Given this list of marker genes Tln1, Pde5a, Myl6, Gucy1b2, Itgb5, Actg2, Tpm2, Myl7, Lmod1, Calm1, Pxn, Myl9, Gucy1b1, Tpm3, here is a description of the gene set: species: Mus musculus electronically inferred by orthology from the curated human pathway This event has been computationally inferred from an event that has been demonstrated in another species.<p>The inference is based on the homology mapping from PANTHER. Briefly, reactions for which all involved PhysicalEntities (in input, output and catalyst) have a mapped orthologue/paralogue (for complexes at least 75% of components must have a mapping) are inferred to the other species. Reactome Pathway: Smooth Muscle Contraction part of: Muscle contraction